The following is a description of a gene set: Mouse Gene Set: GOBP_TRANSCRIPTION_INITIATION_AT_RNA_POLYMERASE_III_PROMOTER species: Mus musculus A transcription initiation process that takes place at a RNA polymerase III gene promoter. Transfer RNAs (tRNA) genes, as well as some other non-coding RNAs, are transcribed by RNA polymerase III., and this is the list of marker genes: Crcp (calcitonin gene-related peptide-receptor component protein), Gtf3c4, Gtf3c1, Bdp1, Gtf3c5, Polr3h, Snapc5